The following is a description of a gene set: studied in species Homo sapiens Binding to a major histocompatibility complex class II molecule; a set of molecules displayed on cell surfaces that are responsible for lymphocyte recognition and antigen presentation. Human Gene Set: GOMF_MHC_CLASS_II_PROTEIN_BINDING, and this is the list of marker genes: LAG3, CD74, CD4, CD81, FCRL6, COL2A1